Given this list of marker genes CIITA, LILRB5, LINC01605, DNASE1L3, LILRB4, CD1C, SLAMF8, CCR1, IFI30, MS4A4E, ADGRE2, HLA-DQB1, CD33, SLC12A3, HCK, VSTM1, P2RY13, NFAM1, ITGAX, IGSF6, HLA-DQB2, FGL2, LILRA1, CD300LF, HLA-DRB1, C1QB, TET2-AS1 (TET2 antisense RNA 1), MS4A6A, CLEC5A, SIGLEC7, LINC01094, MTND5P14, CMKLR1, FCGR1BP, C3AR1, SLC15A3, NLRP3, IDO1, SIRPB1, ASGR2 (NCBI Gene Id 433), C19orf38, CD300LB, ADGRE3, SOWAHD, SLC37A2, CPA3, HDC, TLR8, C1QC, CCDC26, HLA-DQA1, EGR2, CD1D (NCBI Gene Id 912), TMEM106A, PRTN3, CD86, NOD2, FPR3, KCNK13, MNDA, FOLR2, VSIG4, LINC02576, SPI1, LRRK1, PLD4, SLC39A13-AS1 (NCBI Gene Id 127138868), HLA-DRB9, NCF2, HLA-DRB5, CD14, PTGS2, FCAR, HRH2, HLA-DQA2, SIGLEC5, RN7SL288P, GPR141, TIMD4, CLNK, FCN1, FPR1, MILR1, MS4A14, CLEC4F, RETN, NAPSB, PILRA, TLR1, CXCL9, P2RY14, ENSG00000253557, CD74, CEACAM4, ANPEP, SLC24A4, HLA-DPA1, SIRPB2, IL1B, CSF2RA, ENSG00000231873, LRRC25, MS4A4A, LINC03070, LILRB2, RN7SL138P, MMP9, WDFY4, CPVL, CD83, C5AR2, CD207 (CD207 molecule), LGMN, LINC00996, LYZ (NCBI Gene Id 4069), CLEC9A, CD300E, LINC00671, PLA2G2D, SIGLEC14, IRF8, LILRA6, CASP5, SIGLEC11, TGFBI, ASB2, C9, CD209 (NCBI Gene Id 30835), HLA-DMA (major histocompatibility complex, class II, DM alpha), CYBB (NCBI Gene Id 1536), CLEC10A, KYNU, FGD2 (FYVE, RhoGEF and PH domain containing 2), LILRA2, NME8, CD163, MPO, PRAM1, HLA-DPB1, SCIMP, CARD9, RNASE6, NAIP, CD163L1, CXCL10, STYXL2, LINC01478, HLA-DRA, LINC02513, CYTH4, GPR34, C1QA, LILRB3, ATP8B4, HLA-DRB6, TRPM2, NLRC4, FCGR1A, BCL2A1 (BCL2 related protein A1), ADGRE1, MPEG1, KCNMB1, CLEC7A (C-type lectin domain containing 7A), RPL32P1, FLT3, IL1R2, HPGDS, HTR7, HAVCR2, ARL5C, OSCAR, HLA-DQB1-AS1, MS4A7, LILRA5, BATF3, SIGLEC1, MEFV, ZNF415P1, IDO2, here is a description of the gene set: from publication Cao J, O'Day DR, Pliner HA, Kingsley PD, Deng M, Daza RM, Zager MA, Aldinger KA, Blecher-Gonen R, Zhang F, Spielmann M, Palis J, Doherty D, Steemers FJ, Glass IA, Trapnell C, Shendure J (PMID 33184181) Marker genes curated from the annotated cluster as represented in the Descartes Human Gene Expression During Development database. Human Gene Set: DESCARTES_FETAL_LUNG_MYELOID_CELLS species: Homo sapiens The gene expression program underlying the specification of human cell types is of fundamental interest. The study authors generated human cell atlases of gene expression and chromatin accessibility in fetal tissues. For gene expression, the study authors applied three-level combinatorial indexing to >110 samples representing 15 organs, ultimately profiling ~4 million single cells. The study authors leveraged the literature and other atlases to identify and annotate hundreds of cell types and subtypes, both within and across tissues. Our analyses focused on organ-specific specializations of broadly distributed cell types (such as blood, endothelial, and epithelial), sites of fetal erythropoiesis (which notably included the adrenal gland), and integration with mouse developmental atlases (such as conserved specification of blood cells). These data represent a rich resource for the exploration of in vivo human gene expression in diverse tissues and cell types.